Given this list of marker genes PPP1R2, POLR2M, EPS8L2, ZNF704, HOATZ, MAP3K5, HTRA4, SKP1, SYT14, SLF2 (NCBI Gene Id 55719), DIXDC1 (NCBI Gene Id 85458), ATAD2B, E2F7, FANCF, ACTR3, FTSJ1, GAREM1, CREB5, BCCIP, KIF3A, RPAP3, KRBOX1, CA10, UCHL5, GAL3ST1, GPATCH2L, ARHGAP21, FUNDC2, RBM3, SEPTIN7, MAP4K4, GCOM1, TAFA5, NRBF2, LRRK2, RNF217, CRLS1, ENSG00000275895, VSX1, RBFOX1, NEK7, ACVR2B, ENOX1, KMT2E, SCN2A, LONRF1, UBXN2A, PKHD1, SLC26A9, CDK7, U2AF1, ALDH1A2, SCAMP1, RTL8B, TNFSF4, CTNND2, AKIRIN2, SMAD1, HERC3, AZIN1, ZBTB43, FER, AAK1, UCK2, SLC44A2, RHOA (ras homolog family member A), CDYL, COPS5, PROK1, CEBPG, RAP1GDS1, KATNAL1 (NCBI Gene Id 84056), RLIM, LRP2, PARG, MRC1, SKIL, BICRAL, KRT32, AHSA2P, PRDM4, PEAK1, CCDC40, PPA2, BEX4, RSF1, ACTR10, NFAT5, PALMD, FERMT2, PRRC2C, N4BP2L1, DELEC1, H2AZ2, SLMAP, STT3A, SCN7A, DLAT, WDR31 (NCBI Gene Id 114987), TBR1, here is a description of the gene set: Genes predicted to be targets of miRBase v22 microRNA hsa-miR-582-3p in miRDB v6.0 with MirTarget v4 prediction scores > 80 (high confidence targets). from publication Chen Y, Wang X (PMID 31504780) Human Gene Set: MIR582_3P species: Homo sapiens